The following is a description of a gene set: Human Gene Set: GOBP_REGULATION_OF_STORE_OPERATED_CALCIUM_ENTRY Any process that modulates the frequency, rate or extent of store-operated calcium entry. species: Homo sapiens, and this is the list of marker genes: JPH4, SPG11, HOMER1, SARAF, CASQ1, HOMER3, GRAMD2A, SLC8B1, MIR424, EFHB, CD84, HOMER2, SPINK1, STC2, STIM1